Given this list of marker genes MCM7 (NCBI Gene Id 4176), PCDH7, CYP51A1, BIRC5, GTF2H2, KIF11, CENPH, NCAPH, SND1 (NCBI Gene Id 27044), WDFY4, ATOX1, LTA4H, DKC1, KIF15, SLK, MACROH2A1, MYBL1, CLDN1, PRKAG2, LSP1, TAF8, VARS1, AP1M1, RPL27, H2BC14, TAAR2, PROX1, HM13, PDS5A, CD180, ANPEP, LANCL3, RPL18, SOD3 (NCBI Gene Id 6649), NRF1, HSDL1, CYB561A3, ITM2A, PCNX3, FLT3, SMG6 (NCBI Gene Id 80091, SMG6 nonsense mediated mRNA decay factor), NCAPG (non-SMC condensin I complex subunit G), ARHGAP26, EPHX3, RPL14, NUP210, CDK14 (cyclin dependent kinase 14), SLC35E1, PBK, KLHDC4, MYCL, CKS1B, KCTD20, SHMT2, CKB, KNL1, SP100, RAB30, FNBP1, RASGRP3, NUP43, SEPTIN6, DOCK5, LY75, ACACA, TAGLN2, GM2A, N4BP2, PRRC2A, H1-3, BTLA, RTL5 (retrotransposon Gag like 5), COPS7B, CHST15, TBC1D8, EZH2, STRIP2, PRSS3P1, MIR142, ABHD2, AP1S3, CENPE, FBXO21, H4C14, F2RL2, TBC1D1, NAALAD2, MRPS27, PDIK1L, NCAPD3, RAB39A, DNA2, LSM2, GALK2, GCSAM, TGFBR3, MIR380, H4C4, ZEB1, CST7, ANXA6, PCTP, CST3, CS, LMBR1L, IKZF1, SELENOW, LRRK2, YBX3, KNTC1, CDKN2C, TPK1, XCR1, DAPK1, SKAP1, CD8A, PLEKHM3, TMSB10, GPR68, FAM149A, PSMA5, ZFAND4, DTNB, GEN1, SUPT20H, LYST, CLEC9A, NAGA, TACC3, CLIC1 (NCBI Gene Id 257617), SMC4, MKRN1, CD24, PTCD3, AKNA, ZYX, MREG, CCDC88A, C1orf54, ALDH18A1, TNFRSF13C, ESCO2, PPM1M, TPX2, TYK2, TDH, LGALS1, PRC1, KLHL1, CHEK1, MAP4K5, TNNI2, FANCD2, AP2S1, H2AC8, ITGAE, MOB3A, BHLHE40, S100A11, ACTN1, ASPM, GPR179, ASAP1, MRPL49, KIF20B, POLB, HMGN3, ANLN, HTR7, CORO1A, here is a description of the gene set: species: Homo sapiens Genes down-regulated in cells from Flt3L Melanom injected mice: splenic DEC205+ dendritic cells versus B lymphocytes. from publication Dudziak D, Kamphorst AO, Heidkamp GF, Buchholz VR, Trumpfheller C, Yamazaki S, Cheong C, Liu K, Lee HW, Park CG, Steinman RM, Nussenzweig MC (PMID 17204652) Dendritic cells (DCs) process and present self and foreign antigens to induce tolerance or immunity. In vitro models suggest that induction of immunity is controlled by regulating the presentation of antigen, but little is known about how DCs control antigen presentation in vivo. To examine antigen processing and presentation in vivo we specifically targeted antigens to the two major subsets of DCs using chimeric monoclonal antibodies. Unlike CD8+ DCs that express the cell surface protein CD205, CD8- DCs, which are positive for the 33D1 antigen, are specialized for presentation on MHC class II. This difference in antigen processing is intrinsic to the DC subsets and associated with increased expression of proteins associated with MHC processing. Human Gene Set: GSE6259_FLT3L_INDUCED_DEC205_POS_DC_VS_BCELL_DN